The following is a description of a gene set: species: Mus musculus Mouse Gene Set: GOBP_REGULATION_OF_NEUTROPHIL_APOPTOTIC_PROCESS Any process that modulates the frequency, rate, or extent of neutrophil apoptotic process., and this is the list of marker genes: Itpkb, Il18, Pik3cb, Cd44, Cxcr2, Pik3cd, Fcgr2b, Slc7a11, Anxa1, Hcar2